The following is a description of a gene set: Neighborhood of MAPT species: Homo sapiens Neighborhood of MAPT microtubule-associated protein tau in the GNF2 expression compendium Human Gene Set: GNF2_MAPT, and this is the list of marker genes: SYN1, CAMK2N1, SV2A, SCN3B, ADGRB3, GAP43, KIF1B, DOCK3, GNAO1, SNAP91, RTN1, RAB6B, GPM6A, MAPT, DNM1, STXBP1, SLC1A3, PNMA2, PSD3, CLIP3, FXYD7, SH3GL2 (NCBI Gene Id 6456), SV2B, ANK2 (NCBI Gene Id 4028), KCNQ2, ELAVL4, RGS7, PALM, SYT1, NAP1L3, GRIA2, NRXN1, NPTXR, ARNT2, GABBR2, SNCB, DIRAS2, DYNC1I1, RUNDC3A, RALYL (RALY RNA binding protein like), KIF5C